The following is a description of a gene set: IL-5 signaling pathway Mouse Gene Set: WP_IL5_SIGNALING_PATHWAY studied in species Mus musculus, and this is the list of marker genes: Bax, Sh2b2, Raf1, Jak2, Il2rb, Hck, Prkcd, Il5 (NCBI Gene Id 16191), Ptpn6, Cbl, Pla2g4a, Rac1, Stat3, Cdkn1b, Grb2, Il5ra, Rap1gap, Itgam, Mapk1, Mapk3, Rapgef1, Ctnnb1, Lyn (LYN proto-oncogene, Src family tyrosine kinase), Ccnd3, Pik3r1, Btk, Ptpn11, Alox5, Stat5a, Crkl, Jun, Itgb2, Dnm2, Ptk2b, Unc119, Syk, Sdcbp, Mapk14, Map2k2, Mapk9, Shc2, Shc1 (src homology 2 domain-containing transforming protein C1), Ywhaz, Pik3r2, Vav1 (vav 1 oncogene), Stat1, Alox5ap, Gsk3a, Kras, Prkcb, Gsk3b, Rps6ka1, Socs1, Nfkb1, Csf2rb, Foxo3, Elk1, Pik3cg, Nfkbia, Akt1, Stat5b, Atf2, Hcls1, Sox4, Icam1, Pim1, Jak1, Hras (Harvey rat sarcoma virus oncogene)